The following is a description of a gene set: Mouse Gene Set: GOBP_TRYPTOPHAN_TRANSPORT species: Mus musculus The directed movement of tryptophan, 2-amino-3-(1H-indol-3-yl)propanoic acid, into, out of or within a cell, or between cells, by means of some agent such as a transporter or pore., and this is the list of marker genes: Ace2, Slc7a5, Slc3a2, Slc36a4, Slc16a10, Slc7a8